The following is a description of a gene set: The G12/13 family is probably the least well characterized subtype, partly because G12/13 coupling is difficult to determine when compared with the other subtypes which predominantly rely on assay technologies that measure intracellular calcium. The G12/13 family are best known for their involvement in the processes of cell proliferation and morphology, such as stress fiber and focal adhesion formation. Interactions with Rho guanine nucleotide exchange factors (RhoGEFs) are thought to mediate many of these processes. (Buhl et al.1995, Sugimoto et al. 2003). Activation of Rho or the regulation of events through Rho is often taken as evidence of G12/13 signaling. Receptors that are coupled with G12/13 invariably couple with one or more other G protein subtypes, usually Gq. species: Homo sapiens Reactome Pathway: G alpha (12/13) signalling events part of: GPCR downstream signalling, and this is the list of marker genes: FGD2, PREX1, ADRA1D, ROCK2, ARHGEF10L, ECT2, PLXNB1, FGD3, SOS2, OBSCN, GNG4, ARHGEF2, ARHGEF26, NET1 (NCBI Gene Id 10276), ARHGEF33, ARHGEF5, TIAM2, ABR, MCF2L, ARHGEF19, TIAM1, VAV3, ADRA1A, KALRN, ARHGEF39, FGD4, TBXA2R, ARHGEF3, ARHGEF37, PLEKHG2, ARHGEF38, ARHGEF15, RHOC, GNG8, ARHGEF17, GNG3, RHOB, AKAP13, BTK, ARHGEF6, NGEF, GNGT1, ROCK1, GNB4, ARHGEF10, GNB3, ARHGEF16, GNG10, GNB1, ADRA1B, MCF2, GNG13, SOS1, ARHGEF40, ARHGEF12 (Rho guanine nucleotide exchange factor 12), GNG7, TRIO, RHOA, ARHGEF11, GNA13, RASGRF2, GNA12, GNGT2, VAV1, ARHGEF7, GNG11, VAV2 (vav guanine nucleotide exchange factor 2), ARHGEF1, PLEKHG5, FGD1, ARHGEF18, ARHGEF35, ARHGEF4, ITSN1, GNG2, ARHGEF9, GNG12, GNG5, GNB2, GNB5 (G protein subunit beta 5)